Given this list of marker genes COPG1, ITCH, PNO1, DSC2 (NCBI Gene Id 1824), ALDOA, MRPS6, ATP6V1E1, MAN1A2, NPC2, POU2F1, CIAPIN1, RARS1, SLC10A3, IK, BRF2, FAM3C, POLL, RNF138, HMGN5, UBA3, ATXN2L, SP1, ENSA, WDR83, FPGT, SFSWAP, FBXL14, SIRT7, RPS15A, ARL8A, TRIM28, SLC10A7, IFITM2, ROMO1, WDR81, FAM193A, ILF3, MRM2, CAB39, EIF2S1, GLCE, MED16, N6AMT1, NEFH, EIF2B4, SMURF2, LHX3, ECPAS, FIS1, RRP7A, ATP5ME, ZC3H11A, CRAT, ATP1A1, DUSP10, WDTC1, WTAP, AHCYL1, DAZAP1, C1D, ZNF749, MRPL37, WDR5, TAF8, PTPN11, MYO9A, DIP2A, VAMP1, UNCX, CSTB, SRRT, ZMYM6, NELFB, KIF4A, EIF2B3, NF2, NT5DC1, RPL37, AHCTF1, TARS1, SIM2, DGKE, CERK, ARID1A, FAM53B, PFDN6, GRPEL1, RPF1, LYRM2, GRK3 (NCBI Gene Id 157), FAM91A1, PELP1, NAE1, ZNF792, RHAG, TBP (TATA-box binding protein), ATP5MF, RPP21, SUPT4H1 (SPT4 homolog, DSIF elongation factor subunit), SPIN2B, LDAF1, TAFAZZIN, FAM8A1, ZNF688, SFI1, PHKG2, CDK2, TFEB, ATIC, NUMA1, NUDCD1, H3C13, SHOX, RBM19, TMTC4, GCC2, TMEM70, ZNF512, NCBP2, CPSF6, NUBP1, KIFAP3, PTPRA, ABHD10, DYNC1LI2, SURF6, THOC3, GJC1, UBE2O (ubiquitin conjugating enzyme E2 O), FBXO5, PWP1 (NCBI Gene Id 11137), TOP1, VPS26A, TNKS2 (tankyrase 2), COMMD3, HIP1R, MSRB2, PGS1, GRK2, SRP14, COPS7A, COL2A1, MRPL22, SNCG, NPB, SLC1A5, ADD1, SLC7A5, BCL11B, MED29, SMYD5, PDIA4, RHOH, ASF1B, MAGEB1, STX8, RBPJL, ATXN7L3B, SYS1, IFT172, SDC1, RAPGEF2, B9D1, TUFM, SNAI1, RPL29, TRUB2, MKRN3, GOLT1B, DPH6, SOX1, PBX3, ZNF763, POLG, PSMC6, ERGIC3, UTP6, MRPS33, VARS1, TAX1BP1, GAB2, CCDC169, KLHL11, FAM185A, NARS1, SMN2, DNAJC19, KIF5B, ZC3H13, MED18, UPF2, MRPL24, RPL19, ASAP1, RAB10, PXMP2, GALE, METTL2A, UQCRB, GTF2A2, DGCR8, SLX9, CCNB2, CCND1, NDUFA9, CSAG1, GATC, PEBP1, ZNRF1, PHB1, JTB, TRPS1, SLC29A2, WIPF2, DMRTB1 (DMRT like family B with proline rich C-terminal 1), ST6GALNAC6, EPRS1, COPE, MED11, DPF2, CCNF, COPS8, ANXA6, TNFAIP2, AVL9, NIFK, USP5, CNEP1R1, ZFTA, RPS20, HIVEP2, HSPA14, PPA1, ZNF706, TM7SF2, RRN3 (NCBI Gene Id 92636), ITPR2, ATP5PO, CNOT8, MBNL1, CARS2, MED30, POLR1F, ZFP30, APOBR, LLGL1, INTS14, FLOT2, EIF4G3, LRP10, SEH1L, NKX2-8, DCAF11, SPIC, LRIG2, GRHL1, WDR7, SERP1, PKN3, ACTL6A, HES2, GULP1, FSCN1, RPS19, C14orf119, DHX34, NMRAL1, PSMC3IP, DUS1L, KLHL7, RSL1D1 (ribosomal L1 domain containing 1), BET1L, DYNLL2, NCL, PPP1R12A, SDHC, FASN, CYTH3, KIF2A, MAGI3, CREG1, CAPN10, HMBS, ATAD5, EIF2B5, RCN2, RHOBTB1, SLC39A1, ENGASE, SSRP1, ZNF222, RTL8C, RAD21, BBS1, CSRNP3, EPHX2, EEFSEC, POLA1, RABIF, VAMP8, BST2, MAPK6, IER5, MRPS35, RSF1, CAND1, SUPT6H, RNMT, PPCDC, OR2T5, BRD3, POLD4, ZFP36L2, ARID5B, PANX1, SPRY4 (sprouty RTK signaling antagonist 4), IQGAP3, HOXD8, USP22, CTBP2, CCNK, ADRM1, NDUFA2, ELOA, AP1G2, ZNF551, HIGD2A, TADA3, PSMC3, NDUFS3, GTF3C2, TRAPPC11, RNF20, EXOC7 (NCBI Gene Id 23265), RPL12, ZBTB17, TNFRSF1A, C9orf40, E2F8, EIF4EBP2, ARHGAP25, PKIB, PLCB1, TTC33, ZSCAN5B, SAPCD2, ZSCAN30, TBCC (NCBI Gene Id 6903), SACM1L, WDR27, CASZ1, BROX (NCBI Gene Id 148362), USP7, DHRS11, RPN2, DHX37, EMC9, SRP68, COX11, ZNF621, ZNF841, MTHFD1, MED19, MED10, POP5, SUZ12, ANKRD13C-DT, UCP2, ELF3, H2AC16, TOMM34, MRPL55, EIF2B2, MAX, TOP6BL, FOXJ3, MED1, ITGA2B, YARS2, MOV10, LRRC20, ARFGAP3, TMEM273, COPS6, FOXE3, HSPA9, TP53, NAA10, TAL1, DCTD, ZNF331, CHDH, AHCY, VMA21, AP3M2, CPSF3, MORC2, RMND5B, NOL11, CRLS1, SERGEF (NCBI Gene Id 26297), CD3D, NR2F2, AKAP13, RABGAP1L, CAMLG, CREB1, BMAL2, POLD1, ALG2, DNMT1, SMC1A, NOP9, PTPN4, TCF7L1, MRPL10, THAP12, PI4KA, MAPK8, TIMM23B, ZNF669, NOMO1, TULP4, ZBTB8OS, MINDY3, INPP1, STRBP, ZNF639, EEF2, MBD4, MTCL2, RMI1, B9D2, BLTP2, RNF181, CCNE1, NKX1-2, FDFT1, PNKP (NCBI Gene Id 11284), GMIP, ACSL3, POP4, MED6 (NCBI Gene Id 10001), HPS3, PFN1, HEXIM1, TMOD1, HIF3A, RAB8B, TIMM44, RTCB (RNA 2',3'-cyclic phosphate and 5'-OH ligase), PPP2R5A, RBM4, TMEM258, CTSD (NCBI Gene Id 196214), ZNF587B, PARD3, MORC3, LEF1, GTF2H1, LTBR, CAPZA1, CPXCR1, HPS6, PMPCB, NR1H3, ATP6V1E2, TRIM37, SF3B2, MEA1, FIRRM, TRMT1L, ATP6V1B2, CLPB, INO80C (NCBI Gene Id 125476), HSCB, RHPN1 (rhophilin Rho GTPase binding protein 1), SEMA4C, ATP6AP1, RPL23, HSPA8 (heat shock protein family A (Hsp70) member 8), STAC3, DDX17, NRARP, ATP6V0B, NDUFB8, HSP90AB1, NEUROG2, EBPL, FMR1, CCNB1, POLR3F, DHX36, AEBP1, FXR2, DHRS13, TCEAL8, BTF3, OSTF1, SRPRB, PRPF40A, RNF11, TP63, UBE3C, EMC3, MRPL19, LTBP4, SCO1, KAT7, LRRC8B, NACC1, HOXD3, HOXD13, AP1G1, OXLD1, DNASE2, NIP7, RPLP0, ZNF775, RBL1, LAP3, PCSK9, PSMB4, TMLHE, TNFAIP8L1, DHRS3, CAMKMT (NCBI Gene Id 79823), ZNF484, BCAT2, USP11, GATAD1, ARIH1, SDHD, NRIP1, PSMD13, GFOD1, EXOSC2, ATP11B, PFKM, S100A1, SIN3A, ITPRID2, FKBP9, NANS, ZNF814, MICB, STYX, STRIP1, EEF2K, PAK4, RPRD1A (regulation of nuclear pre-mRNA domain containing 1A), KRTAP4-2, HMGCR, ZNF618, ZNF570, MTMR1, MPZ, USP51, ZNF501, CXXC1, RHOXF1, IFT81, FTSJ1, ZNF727, SUPT5H, PARPBP, DAP3, TRMT6, MYCBP2, OPLAH, TBC1D22B, ZNF414, MYF6, FOLR3, TMEM198, ZXDA, SNF8, MGRN1, POLD2, RAB3GAP1, HEYL, AMN1, MRTFA, ERCC2, POLD3, C2orf88, PDZD8, EIF3D, SFPQ, H2AC21, EIF4G1, ZCCHC9, SCRT1, METTL9, RBAK-RBAKDN (NCBI Gene Id 100533952), MED12, H2BC14, ZFP69B, SOX5, FANCA, TXNIP, COX7C, SGSM3, UQCRC2, BATF, TRIP10, URGCP, STRADA, ACO1, PLEKHA4, ZNF385C, RPS29, AKIP1, RNF169, PPP1R14A, RNF220, POLR1B, ATAD3A, ZNF613, ZNF12, GSC2 (goosecoid homeobox 2), NEUROD2, KIAA0232, AIMP1, MYRF, NACA, TERF1, ACSL1, LSM14B, OXA1L, LUC7L3, SAP18, TMX2, PRELID3B, GOLGA6L1, PHACTR2, TRIOBP, TPGS2, DPH1, ANAPC7, TAF1C, KDM3B, DLG5, BUB1, PPIE, EPS15, SENP6, FASTKD3, COMMD6 (COMM domain containing 6), CHEK2, KRT17, RPSA, PIAS3, CDC42EP1, OGA, FOXP1, POLR1C, COPS2, ORC5, CENPO, LYN, CDC25C, KLC1, ASXL1, TM9SF1, PRSS50 (serine protease 50), WIZ, GALNT6, CENPV, TRIM41, MTMR14, EBF1, TNFRSF12A, OXR1, NSD3, RPLP1, ASF1A (anti-silencing function 1A histone chaperone), MRPL40, MPI, BOLA2, GFER, OR7A10, PHF1, IBA57, UBL3 (ubiquitin like 3), FLVCR1, HSPB1, EIF3H, PLXNB2, ASCL2, PRELID1, TCOF1, RESF1, GAD1, APOC1 (NCBI Gene Id 341), SLC6A6, MED17, C1QTNF4, PTPN12, BOD1L1, CDS2, UBE2M, SUSD3 (NCBI Gene Id 203328), DCAF5, SNTB2, INTS10, ENKD1, KLHL21, NR2C1, ZNF84, EEF1G, ZNF655, PLAA, RPL24, DAD1, HMGN1, USP32, TBC1D7, MIX23, FOXO1, SKP1, TOMM5, TTLL4, VPS51, SCRN2, KIAA0930, ZBTB7B, SWI5, POLE2 (NCBI Gene Id 5427), IRF2BP2, NSUN4, SGPP1, MRPL35, SLC25A24 (NCBI Gene Id 92093), LETM1, ZNF622, DYRK1A, RMDN3 (NCBI Gene Id 55177), AKIRIN2 (NCBI Gene Id 55122), CDKAL1, CASP8, RPL36AL, BNIP1, NDUFB10, REV3L, UQCC2, SLC39A8, EIPR1, AP3B1, here is a description of the gene set: Human Gene Set: PULVER_FOREY_PERTURB_ATTRITION_M_EG1 Transcription regulation during the cell cycle is crucial for ensuring genes are expressed at the right time and in the correct amounts, coordinating key processes like DNA replication, mitosis, and cell division. In our study, Genes whose depletion leads to accumulation of cells in M/eG1 (pVal < 0.05) in K562 Repogle et al., 2022 reanalyzed with Velocycle from Lederer et al., 2024 species: Homo sapiens